The following is a description of a gene set: Human Gene Set: GSE17721_POLYIC_VS_GARDIQUIMOD_8H_BMDC_UP Genes up-regulated in comparison of dendritic cells (DC) stimulated with poly(I:C) (TLR3 agonist) at 8 h versus DC cells stimulated with Gardiquimod (TLR7 agonist) at 8 h. mouse primary BMDCs were stimulated with tlr ligands and gene expression changes were profiled on Affymetrix arrays from publication Amit I, Garber M, Chevrier N, Leite AP, Donner Y, Eisenhaure T, Guttman M, Grenier JK, Li W, Zuk O, Schubert LA, Birditt B, Shay T, Goren A, Zhang X, Smith Z, Deering R, McDonald RC, Cabili M, Bernstein BE, Rinn JL, Meissner A, Root DE, Hacohen N, Regev A (PMID 19729616) studied in species Homo sapiens, and this is the list of marker genes: CAMK2D, TOX4, NUDT9, ILK, NTM, ADCY7 (adenylate cyclase 7), IFFO2, CNTRL, SOCS6, SUGT1, SP4, MOV10, CDC42SE1, FLII, MRAP, TPPP3, NRROS, PSD, DHFR, RASA4, RNF135, DCLRE1A, ZC3H3, TPST1, B3GNT8, IRF8, PTS, IP6K1, PTPN18, TMEM101, TTC39B, SNX16, TSC22D3, SUB1, STK39, HMG20B, HEXB, REEP3, HFE, ACTB, NAXE, LRRN1, ATM, SLC44A2, HDDC2, TM2D2, REST, BARD1, DGLUCY, HEBP1, FBLN2, ZFP36L2, ESYT1, CD80, CHCHD7, HLA-B, LRP4, KLF3, SMPD3, HES1, BATF2, TEP1, ARSI (arylsulfatase family member I), ABTB1, GRK1, MCM7, RBMS2, DNAJC8, DYRK1A, RFC2, RGS14, BUB1B, RPL13A, MYL2, AKT3, SSBP3, SLC23A3, C2, LPAR1, SLC30A1, TBC1D13, FAM53A, ANAPC5, NTS, NUF2, CABP2, CD164, RNF115, ADCK1, DNAJC5, STX5, ING2, ISL2, MAGI1, ISG15, IFT74, C6orf58, OGFRL1, SLC66A1, RSRP1, VWA5A, RNASET2, HSPB1, RHOV, IDNK, DHCR7, HSCB, ARRDC4, RNH1, RBMS1, CRISP2, PSME4, OAS2, PTPA, NINJ1, FYN, GPR37, GCA, BNIP3L, CADM3, ASCL2, DGKA, PLA2G2D, TP53INP1, STAT3 (NCBI Gene Id 6774), DHRS7, NRDE2, DDX4, CES1, ART3, MYOM1, TLR4, CAAP1, RGL2, UBAC1, CRAT (carnitine O-acetyltransferase), HTRA1, CLK3, STK4, FAM3C, STARD3, ABCB1, EGR1, UBE2B, MYO9B, OSBPL9, MRC1, ABCG1, SERTAD1, RNPEP, MX2, FBXO4, C11orf68 (NCBI Gene Id 83638), ICA1, CTDSP2, REG1B, TRIM6, IFI30, SLC25A17, IL10RA, ARFGEF1, ADK, SASH3, NFATC1, AZGP1, GRB2, ASF1A, FBXW7 (NCBI Gene Id 55294), KCNN2, FITM1, KDR, GCG, TBL1X, PLXDC1, UTRN, OTX2, HINT2, TNS1 (NCBI Gene Id 7145), MSI2, ANPEP, IGBP1, GLA, CHD4, NLGN2, PCDHB10, ANKIB1, BST2, EPSTI1, APAF1 (NCBI Gene Id 317), ITPRID2, DIO2, S1PR3, MAD2L1BP, NFKBIE, SNX20, PNRC1, ASB11, PLAAT3, PTGER2, ATP13A2